The following is a description of a gene set: Temper tantrums, which occur with more severe symptomatology compared to a temper tantrum that occurs as a part of normal developmental process. studied in species Homo sapiens Human Gene Set: HP_SEVERE_TEMPER_TANTRUMS Severe temper tantrums, and this is the list of marker genes: DPF2, TACO1, SCN8A, RSRC1, GNAI1, WARS2